Given this list of marker genes REL, IFNGR1, GIT2, RHOH, CRYBG1, GCH1, ITPR1, SATB1, MARF1 (NCBI Gene Id 9665), LPGAT1, LYL1, IL4R, BIN1, ELF4, CD37, AHR, MS4A1, HHEX, MMD, MAPRE2, AXIN1, NFKB1, MOB1A, TGFBR2, SERPINB1, BLK, CXCR5, NFKBIE, LTB, GPR18, CIITA, RHOG, HLA-DMB, CCND3, RPS4Y1, TRIM22, CD83, IRF8, here is a description of the gene set: studied in species Homo sapiens Genes down-regulated in plasma cells compared with B lymphocytes. Plasma cells (PCs), the end point of B-cell differentiation, are a heterogeneous cell compartment comprising several cell subsets from short-lived highly proliferative plasmablasts to long-lived nondividing fully mature PCs. Whereas the major transcription factors driving the differentiation of B cells to PCs were recently identified, the subtle genetic changes that underlie the transition from plasmablasts to mature PCs are poorly understood. We recently described an in vitro model making it possible to obtain a large number of cells with the morphologic, phenotypic, and functional characteristics of normal polyclonal plasmablastic cells (PPCs). Using Affymetrix microarrays we compared the gene expression profiles of these PPCs with those of mature PCs isolated from tonsils (TPCs) and bone marrow (BMPCs), and with those of B cells purified from peripheral blood (PBB cells) and tonsils (TBCs). Unsupervised principal component analysis clearly distinguished the 5 cell populations on the basis of their differentiation and proliferation status. Detailed statistical analysis allowed the identification of 85 PC genes and 40 B-cell genes, overexpressed, respectively, in the 3 PC subsets or in the 2 B-cell subsets. In addition, several signaling molecules and antiapoptotic proteins were found to be induced in BMPCs compared with PPCs and could be involved in the accumulation and prolonged survival of BMPCs in close contact with specialized stromal microenvironment. These data should help to better understand the molecular events that regulate commitment to a PC fate, mediate PC maintenance in survival niches, and could facilitate PC immortalization in plasma cell dyscrasias. from publication Tarte K, Zhan F, De Vos J, Klein B, Shaughnessy J Jr (PMID 12663452) Human Gene Set: TARTE_PLASMA_CELL_VS_B_LYMPHOCYTE_DN